Given this list of marker genes MAP2K1, DOCK7, USP8, KRAS, NRG1, SOS1, CDC42, PIK3R3, PRKACA, RNF41, HRAS, AKT1, RAF1, NRG2, NRAS, STAT3, RAC1, SRC, ERBB2, JUN, PIK3CA, FOS, MTOR, PIK3R2, NF2 (NF2, moesin-ezrin-radixin like (MERLIN) tumor suppressor), BAD, PIK3CD, JAK2, ERBB3, MAPK8, MAPK10, MAPK3, MAPK1, SHC1, MAP2K2, PIK3R1, CHRNE, PTPN11, PPP3CB, NFATC4 (NCBI Gene Id 4776), PIK3CB, GRB2, CHRNA1, MAPK9, here is a description of the gene set: ErbB2/ErbB3 signaling events from publication Schaefer CF, Anthony K, Krupa S, Buchoff J, Day M, Hannay T, Buetow KH (PMID 18832364) studied in species Homo sapiens Human Gene Set: PID_ERBB2_ERBB3_PATHWAY